The following is a description of a gene set: Human Gene Set: GOMF_TRANSMEMBRANE_SIGNALING_RECEPTOR_ACTIVITY species: Homo sapiens Combining with an extracellular or intracellular signal and transmitting the signal from one side of the membrane to the other to initiate a change in cell activity or state as part of signal transduction., and this is the list of marker genes: ERBB4, ROBO1, ADGRF4, OR2Y1, CHRNA2, OR1A1, PLXNB3, OR52B2, VN1R3, NOTCH1, OR2M5, LHCGR, OR5AL1, LYVE1, GPR15, OR2D3, OR1N1, LTK, OR4D1, NPR1 (natriuretic peptide receptor 1), OR6C2, LRP5 (NCBI Gene Id 8058), IL17RB, AGTR2, OR6C74, ADRA2A, AVPR1A, OR1P1, IL18RAP, SCN7A, OR10R2, GP6, FCER2, CHRNA5, OR8S1, GABRA1, OR5B12, OR1L1, LPAR3, NFAM1, MET, CD74, PTPRK, OR52N1, OR6P1 (olfactory receptor family 6 subfamily P member 1), EPHA7, PRLR, OR4B1, OR4E1, L1CAM, NPFFR2, FCRL5, OR2K2, TMEM63C, IL7R, OPRM1, OR10G3, DRD3, OR51B2, ROR2, TNFRSF1A (TNF receptor superfamily member 1A), OR52N4, CLEC1B, ADGRG3, PTGER4, GPR50, OR5H8, OR8D1, MRGPRX4, OR7G3, OR1L4, PTPRD, OR10J5, OR2M7, PTGDR2, TLR6, P2RY13, LRP8, TAS2R43 (NCBI Gene Id 259289), OR2T4, MR1 (NCBI Gene Id 3140), NCR2, PTPRO, INSRR, VN1R4, TAS2R5, ADGRG5, OR2T2, TGFBR2, GABRG2, OR6J1, LILRB4, OR1J4, TACR1, OR7C2, OR2A4, ADGRF3, OR14K1, CLEC12A, PROKR1, C17orf99, OR7G2, OR2C1, FGFR4, GPR31, TM2D1, OR14A16, SORCS3, PTPRH, LILRB3, HSPA1A, OR2B3, OR4N4, HBEGF, OR5L2, CRHR1, OR14I1, OR4M1, OR5V1, FCGR2C, CX3CR1, TAS2R39, APLNR, GCGR (glucagon receptor), TMEM63A, OR9I1, OR1D2, PTPRU, LILRA4, BCAM, TMEM35A, GNAT2, ADGRL4, IL17RA, OR1S2, CXCR5, KIR2DL4, PTPRZ1, IL1R2, TAS1R3, EPHA6, EDNRA, GPR148, OR52L2P, HTR2A, OR6B1, MCHR2, OR7A2P, TGFBR3L, GPR37, GLRB, P2RY2, HJV, GPR22, VN1R17P, CCR3, OPRD1, OR5AU1, TACR2, OR52M1, OR52B4, OR10J1, OR5G3, OR5K2, FZD7, OR4F4, CHRNA4, TNFRSF10B, GPR18, OSCAR, OR2AG1, FCAR, OR2T33, CCR4, OR52E8, EFNA3, TREM1, OR5B2, PTK7 (protein tyrosine kinase 7 (inactive)), EFNA5, DRD1, EGFR, CLEC4A, GPR75, OR51D1, PDGFRA, OR13C4, CHRM3, TNFRSF1B, OR6V1, CCR10, SLURP2, TNFRSF10C, TAS2R50, IFNGR2, RAMP2, S1PR5, HTR3C, MC2R, GABRQ, GPR42, CHRNB2, OR4D10, SCARF1, OR9Q1, KIR3DL1, OR5H15, MRC1, TSHR, OR51I1, GALR3, IL20RA, IFNAR2, FLT3, GPR156, IL12RB2, TAS2R41 (NCBI Gene Id 259287), OR7A10, OR6Q1, NRP2, GRIK1, TGFBR1, CDK5, LILRA5 (NCBI Gene Id 95091), OR10G2, SIGMAR1, GPR21, HLA-DQA2, PTPN6, NRXN3, OR9A4, PKD1, LPAR1, GPR139, OR4S1, OR2T35, LYPD6, SEMA4D, TRPA1, OR2AK2, NPY5R, GPR151, CR1, INSR, HTR1B, OR1E1, GPER1, AGER, SORL1, GPR101, OR2W5P, OR10K1, OR13C7, OR10S1, OR3A1, OR5C1, VLDLR, OR13C9 (NCBI Gene Id 81375, olfactory receptor family 13 subfamily C member 9), NPY, GABRD, AREG, HLA-DRB1, PLXNA2, TAS2R3, OR2V2, OR4C13, TREM2, GABRG1, OR10A2, GPR199P, OR51A7, TACR3, OR52E1, TLR5, OR10G6 (olfactory receptor family 10 subfamily G member 6), OR1D4, SSTR4, SLC22A17, OR4K2, CD200R1 (NCBI Gene Id 131450), IGF1R, GLP2R, GPR4, OR4K17, RET, PDGFRB, KLRC4, EFEMP1, IL2RA, GPRC5D, FCAMR, EPHA4, CD300C, OR13F1, OR51J1, OR5M8, OR2L13, OR52I1, FCRLB, KLRD1, OXTR, SLURP1, OR10C1, OR4M2B, OR1F2P, GFRA1, PSCA, TNFRSF19, OR2T11, RTN4R, OR13J1, OR4M2, OR4C16, OR51G2, TRPV4, PTH2R, KDR, HTR3D (5-hydroxytryptamine receptor 3D), TNFRSF14, OR7D2 (olfactory receptor family 7 subfamily D member 2), VN1R1, OR5AR1, ADGRB1, OR10AG1, CNTFR, RRH, OR10G4, OXGR1, ADGRL2, HLA-DQA1, GABRA6, PTH1R (parathyroid hormone 1 receptor), ADORA3, PLXNA4, HMCN2, PAX8, PLXNB2, TAS2R14, LILRB1, MST1R, OR2T5 (NCBI Gene Id 81460), ADGRF2P, NPY6R, GABRA5, MRGPRG, CD3D, OR13C5, OR10J3, GNRHR, FCGR3A, HCAR2, OR8G3P, OR2L3, PRLHR, OR1A2, OR1J1 (olfactory receptor family 1 subfamily J member 1), OR5A2, OR2AJ1, OR2B6, PDGFRL, PTPRR, GPR34, OR5B17, ADGRE5, AMHR2, OR8B12, TAS2R10, ADGRA1, RHO, OR2B8P, KLRC2, MRGPRE, GPR17, GABBR1, OPN5, ANTXR2, P2RX4, P2RY11 (purinergic receptor P2Y11), OR11H12, OR1N2, OR6C3, OR4K14, OR2H1 (NCBI Gene Id 81408), IGSF6, ROBO2, LAG3, VN1R5, CXCR4, NPBWR1, TREML1, OR52J3, OR4F15, OR6K3, OR13A1 (NCBI Gene Id 79290), TAS2R60, CHRNB4, CD44, OR9A2, GPR26, OR5J2, OR2T29, OR6C70, CRHR2, FCER1G, LILRA1, FCRL4, FCRL3, CLDN4, FLT1, GRM8, OR6M1, CD3E, OR4K3, UNC5CL, OR9Q2, OSMR, IL17RD, OR52E5, CD300E, OR8B3, HRH2, NMUR2, OR10G8, FCGR2B, FLT4, TAS2R9, C5AR1, OR7E24, TAS2R30, FCGR1BP, FGFR2, EDAR, P2RX7, GRM4, OR2I1P, OR12D3, F2RL1, EPHB2, OR8H2, GFRA4, PTAFR, TAS2R19, HTR7, KLRC4-KLRK1, OR6N2, NPY4R2, GPR87, ADGRL3, IL31RA, IL1RAP, OR8K5, ACKR3, TLR3, VN1R2, ADGRA2, FCER1A, OR5W2, P2RX1, ADRA1D, ADGRD1, GLRA2, CYSLTR1, P2RX3, HCRTR2, NTRK1, ERBB3, NPSR1, OR2G3, OR9G4, TAAR1, TAAR5, OR51V1, CXCR6, TAAR6, OR2B2, GPR141, ZACN, GABRR1, PLXNA3, NPY4R, LILRA6, DRD5, OR2J3, OR52B6, OR5P2, OR6K6, TAS2R42, VIPR1, GPR146, GPR32, GPR160, LGR4, EDNRB (endothelin receptor type B), OPN3, OR51A2, PLXNC1, C5AR2, OR5AP2, CD27, FCRL1, GABRB3, LMBR1, OR5P3, OR11H1 (olfactory receptor family 11 subfamily H member 1, NCBI Gene Id 81061), GPR68, LPAR4, OPRL1, CSF3R, GPBAR1, HLA-DQB1, OR51F2, HTR3B, OR8U3, KIR3DS1, GLRA3, KLRF1, CCR8, OR8H3, OR13C6P, CXCR2, HRH3, MAS1L, CHRNA6, GRIN2D (glutamate ionotropic receptor NMDA type subunit 2D), OR11G2, GRM7, RXFP3, GABRG3, DRD2, FZD8, KCTD16, TAS2R1, GPR84, TAS2R13, CCKBR, GREM1, OR56A4, OR2S2, ADRA1A, OR10AC1, LTB4R2, UNC5A, ADGRG1, OR1K1, CHRNA1 (cholinergic receptor nicotinic alpha 1 subunit), OR11L1, SSTR3, EPHB6, CLEC1A, PATE1, FCRLA, CD69, OR8A1, OR6C76, GABRB2, OR10G9, HTR1F, OR2W3, OR1E3, GRIA3, OR4A47, GRM5 (NCBI Gene Id 2915), GABRA2, GPR52, OR1Q1, TPRA1, OR2F1, GRIN2B, GPR32P1, IL13RA1, OR2W1, OR51H1, OR10D3, OR2AT4, CD14, OR5D18, TAS2R31, HCAR1, MARCO, KREMEN1, CD3G, EPHA3, F2RL3, GAL, OR10A7, OR1F12P, OR4A16, NRXN1, EPHB4, OR5AC2, GRID1, TAAR3P, LY6E, GPR171, SSTR1, OR51B5, OR2A14, CR2, IL5RA, GPR119, FPR2, NTSR1, OR2T10, FFAR2, GPR83, GPR132, ROR1, NPC1, OR3A2, OR2L2, GABRP, GPR161, P2RX2, OR51A4, OR56A3, OR52R1, CRCP, VEGFA, OR2A1 (olfactory receptor family 2 subfamily A member 1), SSTR2, GHR (growth hormone receptor), OR6B3, IL12RB1, CCR6, FZD9, OR4F6, OR4A4P, HCAR3, TNFRSF8, OR2G6, OR10T2, CHRM2, OR1D5, ITGB2, OR4K5, CD72, FZD10, CD4, OR7A17, OPN1MW2, P2RX5, ADRB2, SPHK1, OR10K2, GRPR, ALK, OR1C1, EFNA4, CMKLR2, LPAR6, FZD3, OR52A4P, OR14J1, MC5R, ADGRD2, HAVCR2, LILRB2, AVPR2, SORCS2, DCC, OR11H2, EPHA8, GRIA1, DGKQ, OR5T2, OR51E2, FCGR3B, ACVR2B, OR6C6, GPR88, RAMP3, SOSTDC1, OR4E2, GABRE, P2RX6, OR11H7, GPR176, OR8D4, S1PR4, TAS2R16, F3, PECAM1, OR2J1, ADGRF5, OR13H1, OR4X2, GALR1, OR8B8, OR2J2, OR2A5 (olfactory receptor family 2 subfamily A member 5), OR13C3, SCTR, ADGRG7, CD79B, OR8B2, LRP6, PKD2L1 (polycystin 2 like 1, transient receptor potential cation channel), ELOVL4, LIFR, CD300H, RXFP2 (relaxin family peptide receptor 2), TLR2, GPR153, HTR1A (5-hydroxytryptamine receptor 1A), OR5M3, HTR4, OR56A5, TAAR8, HRH4, GPR61, OR5M1, PTPRE, CMKLR1, ADRA2B, FGFRL1, OR5D14, HRH1, MCHR1, PLXNB1 (NCBI Gene Id 5364), PTPRG, OR56B4, GABRA3, CNR2, GPR27, OR52N2, EREG, MRGPRX3, TNF, FZD4, UTS2R, GRIK2 (NCBI Gene Id 2898), OR5B3, MRGPRD, OR6N1, IL11RA, OR1L8, SPHK2, OPN4, HLA-DOA, OR4F3, IFNLR1, ICAM1, OR2T1, TGFA, TGFBR3, ABCC9, OR10Q1, GRM6, EVI2A, OR4C15, CHRNE, IL1RL1, OR9K2, KIR2DS2, NLRP6, LPAR5 (lysophosphatidic acid receptor 5), EPOR, HLA-DQB2, CELSR1, ADGRG6, OR52Z1P, GPR143, GPR39, GALR2, GPR157, CLEC2D, TLR1, SIGLEC8 (sialic acid binding Ig like lectin 8), OR7D4, TRGC2, APP, GNRHR2, OR8H1, ENG (endoglin), OR6K2, ANGPT4, OR5H2, OR2T7, IL21R, OR8J1, OR6A2, OR51Q1, GPR149, ABCA1, AGTRAP, OR14C36, OR5F1, OR5L1, OR2T3, ADGRV1, GRM3, OR2M4, GHSR (NCBI Gene Id 92434), P2RY1, OR10X1, OR52D1, TBXA2R, KREMEN2, OR4A8, TLR4, GPR152, GLRA1, SLC39A9, OR6S1, IL2RB, CCR2, GPR78 (G protein-coupled receptor 78), GLP1R, GP1BA, VIPR2, OR5BS1P, PTGER2, CXCR1, FFAR1, GABRR2, LYNX1, OR9G1, CHRM1, ITGA11, FSHR, IL17RE, CD7, IL23R, MERTK, GRM1, CCKAR, OR4A15, OR10A3, SPN, FFAR4, ADRB3, OR2L5, UNC5B, OR11A1, OR8J3, GPR135, NPY1R, GPR19, OR3A3, IGF2, OPN1LW, OR2M2, CLEC4M, GPR82, SELE, OR2T6, GPR63, PTPRC, HTR2C, OR5AK2, FGFR1, TAPT1, OR6X1, ADRA1B, GPR12, ACVR1B, EDA2R, TAS2R38, IL13RA2, OR52W1, OR4C46, GPR183, CHRNA3, IL18R1, LGR5, OR2AP1, AVPR1B, OR52E6, OR2AE1, KISS1R, OR5M11, CD300LD, DRD4, OR4P4, TAS2R20, OR2F2, INPP5K, GRIN2C, OR10V1, ACVR1C, P2RY10, P2RY8, PATE4, BDKRB1, ADGRB3, EGF, OR4F16, OR8J2, PTPRT, PTCH2, NRXN2, OR51F1, OR8U8, OR6C65, QRFPR, PTCH1, OR2A12, MAS1, HCRTR1, OR2A2, OR5H14, CRLF2, FCRL2, IL12B, GFRAL, OR13C2, GPRC5C, HLA-DPA1, OR4K13, ADORA1, OR14L1, FZD6, OR51B4, IL20RB, OXER1, OR2T27, OPN1MW3, GRIN3A (NCBI Gene Id 138370), KIR2DS1, THBD, KIT, ALKAL2, UNC5D, ADGRG2, GPR65, RAMP1, RORB, HTR5A, ADCYAP1R1, ANTXRL, OR56B2P, MTNR1B, SSTR5, OR4C12, OR10H1, NPR3, OR51B6, GRIN2A (glutamate ionotropic receptor NMDA type subunit 2A), NPY2R, DNER, NMUR1, OR5K4 (NCBI Gene Id 403278), CD300LG, KIR2DS5, OR12D2, CHRM4, HLA-DRB3, P2RY12, LGR6, LYPD1, GPR174, LILRA3, IL3RA, PTGDR, OR7C1, OR5H6, OR5K1, PTPRF, TNFRSF4, OR51E1, PTGIR, GPR20, CCR7, ADRB1, HTR2B, OR10Z1, GPR33, OR6C1, EDA, ADGRF1, OR4C11 (olfactory receptor family 4 subfamily C member 11), GABRA4, OR52P1, NPFFR1, OR4D2, CD300LB, BMPR1A, TAAR9, CELSR2, TAS1R2, HTR3A, OR6C75, IL6R, OR8K1, KLRC1, OR2L8 (olfactory receptor family 2 subfamily L member 8), CD160, GRIA4, FPR3, OR2W6P, KLRC3, FZD5, OR5T1, OR1I1, GRIN3B, HLA-DOB, OR8B4 (olfactory receptor family 8 subfamily B member 4), DDR2, OR13G1, OR52E4, TNFRSF11A, ROS1, CSF2RB, FZD1 (NCBI Gene Id 8321), GRIN1, AXL, CCR1, OR5I1, CCR5, OR2M3, OR7G1, EPHB1, GRIA2, OR1F1, OR4D9, TEK, OR6C4, OR5AC1, OR2A25, LTBP4, OR8G1, ACVR1, OR5M9, GPR142, OR10D4P, XCR1, IGF2R (NCBI Gene Id 3482), OR6F1, EPHA1, GRM2, NGFR, NRP1, OR2T34 (NCBI Gene Id 403243), HLA-DRA, ANTXR1, PROKR2, OR51G1, NRG1, CHRNB3, OR4N5, MTNR1A, OR5AS1, IL17REL, CALCRL, GPR85, ADGRE1, NTRK2, GRID2, MC3R, IL10RB, OR51T1, OR4F29, OR52E2, OR1G1, OR6Y1, GPR37L1, OR2A42, OR4C45, IL1R1, OR52L1, EFNB3, BDKRB2, OR2AG2, PTPRM, ABCA7, OR8D2, OR2H2, OR4X1, CHRNA10, OR56A1, OR4N2, GIPR, IGF1, CTSH, MC4R, GFRA3, OR10G7, GPR173, CHRM5, OR1L6, OR2A7, MRGPRX1, TRHR, IL4R, GRIK5, INTS6, OR2B11, MLNR, OR52I2, GABRB1, OR2V1, ACVR2A, MC1R, LPAR2, EPHA5 (NCBI Gene Id 7304), FCGR1A, TAS2R46, HTR6, OR10H2, FAS, LILRA2 (NCBI Gene Id 11027), GPR3 (NCBI Gene Id 2827), RXFP4, CNR1, GFRA2, OR11H4, OR14A2, GPR182, OR5D13, LMBR1L, UNC5C, OR4K1, OR1B1, SUCNR1, SPDYE11, GPR6, IL6ST, OR5AN1, F2RL2, PPARG, OR4F21, ERBB2, MRGPRF (NCBI Gene Id 219928), CALCR, TNFRSF10D (NCBI Gene Id 8793), CCR9, IL27RA, OR10H3, ADGRE3 (adhesion G protein-coupled receptor E3), GRIK4, P2RY14, CLDN3, GPR158, ABCC8, PLXNA1, OR51C1P, OR6C68, OPN1MW, CHRNG, MYOT, LILRB5, OR4K15, OR4Q3, CRIM1, BTC, S1PR2, NRG3, OR5AK3P, P2RY6, IL15RA, FBXW7-AS1, GPRC6A, BRS3, OR4F5, HTR1E, OR7A5, OR11H6, ADGRL1, TAAR2, GP1BB, OR51I2, ADORA2B, S1PR1, OR52K2, GPR179, PTPRA, SORCS1, NMBR, OR4D6, ACKR4, NPBWR2, FZD2, OR1S1, LY6H, CYSLTR2, FCRL6, TAS2R4, ACVRL1, IFNAR1, GABRR3, PTGER3, CHRNA7, TYRO3, MILR1, ADGRG4, TAS2R8, GPR62, EBI3, ITGA2 (integrin subunit alpha 2), OR10A4, GPR35, CD300LF, ACKR1, CXCR3, FCGR2A, OR5T3, IL17RC, OR12D1, OR2G2, OR56B1, OR2D2, TRPV1, OR13C8, OPRK1, NTSR2, TAS1R1, BMPR2, OR10H5, OR52A5, CHRND, IL10RA, OR4A5, OR8K3, ADORA2A, PTGER1, CD300A, OR4C3, OR52A1, ITGAL, HPGD, IL22RA1, PTGFR, IFNGR1, LY6S, TSPAN12, LYPD6B, OR4C5, OR10A5, SORT1, TMIGD3 (transmembrane and immunoglobulin domain containing 3), OR5A1, ADGRB2, CHRNB1, TLR10, OR5B21, ADRA2C, OR4D11, IL22RA2, GPR162, HTR3E, SLAMF1, B9D1, MPL, KLRB1, OR6T1, F2R, EPHA10, OR5M10, OR10J4, PIGR, CD247, OR9A1P, ADGRE2, TAS2R7, OR1L3, OR51L1, CCRL2 (NCBI Gene Id 9034), OR2Z1, FPR1, IL9R, EPHB3, OR8U1, OR9G9, OR8I2, ACKR2 (NCBI Gene Id 95073), LY6G6D, ALKAL1, TAS2R45, EPHA2, OR2T8, OR10A6, OR2C3, CD79A, OR10W1, OR8G5, KLRK1, TNFRSF25, M6PR (mannose-6-phosphate receptor, cation dependent), HTR1D, MUSK (muscle associated receptor tyrosine kinase), OR8U9, OR6B2, AGTR1, RGR, FFAR3, OR1M1, OR10J6P, DDR1, LTB4R, OR4D5, PKD1L3, PTPRN2, OR52K1, OR10H4, LEPR, OR4F17, IL1RL2, GHRHR, NTRK3, CHRNA9, BMPR1B, OR1E2, IL1RAPL2, PTPRB, GPR25, FCMR, RYK, C3AR1, CSF2RA, FGFR3, IL2RG, ZNF219, TMEM63B, NGF, GABBR2, CASR, OR10P1, TAS2R40, P2RY4, OR8G2P, OR4L1, OR52H1, OR10AD1 (olfactory receptor family 10 subfamily AD member 1), OR5K3, OR51M1, GPRC5B, OPN1SW, SCARB2, GPR150, LTBP1, TNFRSF10A, OR5D16, RXFP1, GPR55, OR1J2, OR13D1, S1PR3, OR51S1, OR5H1, CRLF1 (cytokine receptor like factor 1), CHRFAM7A, GRIK3, MRGPRX2, TNFRSF18, TIE1, OR52N5, ADGRA3, OR4C6, CELSR3, PLXND1, EPGN, OR2T12, GPRC5A, GPR45, CSF1R, OR4S2, SMO, ANXA9, LANCL1, OR4Q2